The following is a description of a gene set: The chemical reactions and pathways involving inositol, 1,2,3,4,5,6-cyclohexanehexol, a growth factor for animals and microorganisms. Mouse Gene Set: GOBP_INOSITOL_METABOLIC_PROCESS studied in species Mus musculus, and this is the list of marker genes: Isyna1, Itpka, Mecp2, Ppip5k1, Ppip5k2, Impa1, Impa2 (inositol monophosphatase 2), Ip6k1, Slc5a3, Miox